The following is a description of a gene set: species: Mus musculus Mouse Gene Set: GOCC_HAUS_COMPLEX A protein complex that localizes to interphase centrosomes and to mitotic spindle tubules and regulates mitotic spindle assembly and centrosome integrity; in human, the complex consists of eight subunits, some of which are homologous to subunits of the Drosophila Augmin complex., and this is the list of marker genes: Haus4, Haus6, Haus8, Haus3, Haus5, Haus2, Haus7, Haus1